The following is a description of a gene set: The chemical reactions and pathways resulting in the formation of acetyl-CoA, a derivative of coenzyme A in which the sulfhydryl group is acetylated. species: Mus musculus Mouse Gene Set: GOBP_ACETYL_COA_BIOSYNTHETIC_PROCESS, and this is the list of marker genes: Dld, Mpc2, Pdhx, Pdk1, Mlycd, Ppcs, Pdha1, Acss1, Mpc1, Acat1, Pdk2, Acss2, Dlat, Pdk3, Bckdk, Dip2a, Vdac1, Acly, Tpk1, Pdha2, Pdk4, Pdhb, Pgk1